The following is a description of a gene set: Any process in which a protein is maintained in a specific location in a mitochondrion, and is prevented from moving elsewhere. studied in species Mus musculus Mouse Gene Set: GOBP_MAINTENANCE_OF_PROTEIN_LOCATION_IN_MITOCHONDRION, and this is the list of marker genes: Pink1, Akt1, Hk2, Hk1, Tspo